Given this list of marker genes USP32, TMCO1, HERC2, FBXL12, DLG1, NUDT15, HPF1, GAA, WDR12, IFT74, LRRC8D, MBNL2, HNMT, ZNF580, MID1IP1, CREBL2, ATM, ZNF202, HECTD4, TJAP1, ATP6V1C1, ANAPC5, NEU1, ASPH, KLHL11, RIPOR2 (NCBI Gene Id 9750), RAB3GAP2, ZNF106, CASP2, OAZ2, CPPED1, BCL2, UBE3B, DCAF13, ATG4A, GAS2L1, MCM3AP-AS1, EIF2B4, SMG1, BORA, DEXI, IPCEF1, MAN2A1, SEC23B, UBE2V2, TTBK2, ZNF277, FBXO28, EXOC5, CD1E, ATF2, SRPK2, BCCIP, PDGFC, CCND3, C6orf120, MGAT2, JADE1, DCLRE1B, SLC15A2, MTRR, PRKAG1 (NCBI Gene Id 5571), GABPB1-IT1 (NCBI Gene Id 55056), MEAF6, STK3, IL13RA1, RETREG2, MRS2, ALG13, MAP3K12, FBXL14, RAB4A, MMS19, ST6GAL1, TIA1, WBP1L, APOOL, ZMPSTE24, KDM3B, KLF6, ZNF225, ATR, MSL2, TOPBP1, DEGS1, NRBF2, CDC73, AZI2, SIKE1, SEC24A, UGDH, ZNF45, MED20, HNRNPUL2, ACO1, EPM2A, FASTKD3, CCL3, CNOT1, CCL4, FAM13A, TNFAIP1, CHUK, ELP5, OTULINL, RAB33B, NAALAD2, DHX16, WIPF1, NABP1, TNFAIP3, IER2, SMARCC2, MYCBP, KRT10, PRPSAP1, GCSH, NPAT, MERTK, ANKLE2, MRPL15, MAPKAPK5-AS1, IRS2, SLC16A1, CSPP1, HSPA1A, RABEP1, GIMAP4, SLC25A24, PKNOX1, CCDC25, CD33, HEATR3, WDR7, CEPT1, UBR4, TTC9, CTPS2, TBC1D22A, CX3CR1, RTCB, TERF2IP, FLI1, TTC27, ARFIP1, COX20, TMBIM1, VPS54, PNMA1, PTX3, FYN, SLC25A40 (NCBI Gene Id 55972), SLC16A3, CXCL1, SETX, ZNF329, GOSR2, HIPK2, ABHD2, FPR3, CLIP1, TCP11L1, AK2, DYNLL1, ERMP1, LIMK2, GPATCH1, SLC35A5, TSNAX, CPM, GEMIN2, RASSF4 (NCBI Gene Id 83937), HACD2, ENTPD1, ZBTB11, ABCB7, TOB2, PTGER4, ARHGAP19, TTC3, TBC1D8, FKBP5, EXOSC10, BCAP29, ZMYM6, ENC1, JUN, NRG1, C1QBP, TSC22D3, AREG, CCT2, MEF2C, ZBTB10, GNPDA1, SMC5, SWAP70, IPO5, GALC, RGL2, ZNF780B, TRIT1, DNPH1, TAF12, FCF1, CTDSP1, CNOT3, PRPF40A, MON2, RESF1, TLR6, CEP57, NDUFB6, LIMS1, RHOT1, GPATCH4, IL4R, ANG, GGA3, CD93, RAB9A, CRISPLD2, EREG, PPP1R10, NCOR1, ENGASE, F5, TMPO, SLA, GALNT2, PSMD14, DICER1, PCF11, IRAK1, CRTAP, KDM2A, SERP1 (NCBI Gene Id 27230), LYRM4, IFNGR1 (interferon gamma receptor 1), MLX, CPT1A, HSD17B12, BAZ1A, STK38L, UBE2I, CD86, RO60, CCSER2, ZFP36L2, ACACB, RTN1, IDS, MAPK1IP1L, CNOT6, RASA4, RNF111, VAT1, SPOUT1, ZNF354A, CD163, GORASP2, TTC17, MAU2, NDUFA6, MTSS1, UBE4B, KIDINS220, MRPL3, DMXL1, PLAUR, TNF, RNASE4, ERI2, FUCA1, PIBF1, PTPN12, TMT1A, HOXA7, LPAR1, CIITA, DUSP6 (dual specificity phosphatase 6), ENOX2, PTGS2, YBX3, ZNF780A, ARAP3, FCAR, BMP2K, ANKS1A, EGR1, GEMIN4, MRPS31, GNL3L, GADD45A, CCR2, KLHL18, MLXIP, DDX18, NME1, EGR3, CAND1, MTDH, CPD, TBC1D5, OLFM1, IPO7, SRPRB, EIF1AX, IFFO1, TOR1AIP1, PURA, CCDC88C, NOLC1, ZNF226, HAL, APPBP2, PTEN, ASB13, OGFOD1, SULT1A2, IBTK, CD9 (NCBI Gene Id 928), FASTKD1, UBL3, TRIM5, ADNP, TCP1, WWP1, EPRS1, ERLIN2, EBAG9, MBP, APAF1, IRF4, ARMC8, ZFP64, MINK1, WBP4 (WW domain binding protein 4), DUSP2, CYB5R1, TNFSF10, CXCL3, RNF146, BRCC3, BTD, THOC7, GNPTAB, TRRAP, MAN2C1, HIPK3, TRPS1, SIGLEC7, MDM2, BBS9, ITPR2, AKAP13, NOP14-AS1, PLXNC1, VBP1, OGFOD3, ZFAND5, ASRGL1, NAIP, MBNL1, ADAMTSL4, TOR1A, IFRD1, CYBRD1, ANKRD17, ETNK1 (NCBI Gene Id 55500), ETS2, GFOD3P, NR4A2, CAPN3, MRPS30, IL27RA, SS18L2, C5AR1, ZNF146, TCTN3, EFHC1, ITGA6, MICAL2, VNN1, ALDH3A2, DNAAF2, PUS7, IL6, VAMP4, FKBP1A, DERA, ESYT1, ASF1A, TASOR, DPP8 (dipeptidyl peptidase 8), TBL1X, TGFBRAP1, HIP1, TLR8, ZNF224, PUDP, OXR1, RPE, MRPS14, RNASE2, SAP30, ZNF32, PFAS, LAIR1, TAX1BP1, INPP5A, ADGRA2, PKP4, KLF2, RCAN1, TRAPPC10, DCAF10, STAM2, SDAD1, SEC63, LCMT1, PTGS1, TCF3, NEU3, HSPA1B, CCL3L3, IRAK3, CLN5, TM2D1, ARFGEF2, PHF20, DNAJB2, MTR, IL10RB, CLEC2D, PID1, DNAJB1, PHLDA2, PBXIP1, MNDA, MCTP1, GIMAP6, TRAPPC8, UGGT2, FBXW2, PREB, MAFF, TMEM184C, RCHY1, ZBTB40, LYST, SMPD4, CAP1, MRPL24 (NCBI Gene Id 79590), SMCO4, IARS1, ATP6V1B2, PAFAH1B1, PIK3C2A, PTPN22 (NCBI Gene Id 5779), TPM1, GIMAP5, NR4A3, MS4A4A, IVNS1ABP, C1orf50, EGR2, GLO1, CSF2RA, NID1, XRCC4, CXCL8, SNAPC3, MTERF3, TNFRSF1A, RAP1GDS1, PREPL, here is a description of the gene set: Human Gene Set: NAKAYA_MONOCYTE_FLUMIST_AGE_18_50YO_7DY_UP studied in species Homo sapiens from publication Nakaya HI, Wrammert J, Lee EK, Racioppi L, Marie-Kunze S, Haining WN, Means AR, Kasturi SP, Khan N, Li GM, McCausland M, Kanchan V, Kokko KE, Li S, Elbein R, Mehta AK, Aderem A, Subbarao K, Ahmed R, Pulendran B (PMID 21743478) Here we have used a systems biology approach to study innate and adaptive responses to vaccination against influenza in humans during three consecutive influenza seasons. We studied healthy adults vaccinated with trivalent inactivated influenza vaccine (TIV) or live attenuated influenza vaccine (LAIV). TIV induced higher antibody titers and more plasmablasts than LAIV did. In subjects vaccinated with TIV, early molecular signatures correlated with and could be used to accurately predict later antibody titers in two independent trials. Notably, expression of the kinase CaMKIV at day 3 was inversely correlated with later antibody titers. Vaccination of CaMKIV-deficient mice with TIV induced enhanced antigen-specific antibody titers, which demonstrated an unappreciated role for CaMKIV in the regulation of antibody responses. Thus, systems approaches can be used to predict immunogenicity and provide new mechanistic insights about vaccines. Genes up-regulated in monocyte 7d vs 0d in young adults (18-50) after exposure to FluMist, time point 7D